Given this list of marker genes Pef1, Birc2, Fancm, Ubb, Pdcd6, here is a description of the gene set: species: Mus musculus Any process that activates or increases the frequency, rate or extent of protein monoubiquitination. Mouse Gene Set: GOBP_POSITIVE_REGULATION_OF_PROTEIN_MONOUBIQUITINATION